The following is a description of a gene set: Irregular or changing caliber (diameter) along the tail of the sperm. Human Gene Set: HP_IRREGULARLY_SHAPED_SPERM_TAIL Irregularly shaped sperm tail studied in species Homo sapiens, and this is the list of marker genes: CFAP91, TTC21A, IFT74, CFAP251, DNAH8, CCIN, STK33, DNAH10, DNAH1, CFAP47, CFAP61, BRWD1, DNHD1, SSX1, CCDC34, FSIP2, WDR19